Given this list of marker genes Trim12a, Cd74, Trim11, Tmprss4, Trim38, Cd4, Hs3st5, Trim30d, Ch25h, Lgals1, Hmgb1, Nectin2, Trim62, Trim30c, P4hb, Trim25 (tripartite motif-containing 25), Tmprss2, Furin, Smpd1, Trim30b, Trim30a, Trim12c, Bsg, Trim5, here is a description of the gene set: Any process that modulates the frequency, rate or extent of the viral entry into the host cell. Mouse Gene Set: GOBP_REGULATION_OF_VIRAL_ENTRY_INTO_HOST_CELL studied in species Mus musculus